Given this list of marker genes Ikbkb, Hnrnpa2b1, Ncoa1, Spink5, Ppp3r1, Clasp1, Fam216b, Wnk3, Dyrk3, Alkal2, Klf4, Arpp19, Acvr1, Rlim, Meox2, Frmpd4, Frmd4a, Plekho2, Pgap4, Dcun1d5 (defective in cullin neddylation 1 domain containing 5), Urb2 (URB2 ribosome biogenesis 2 homolog (S. cerevisiae)), Slc5a7, Ppfibp2, Grpel1, Nmral1, Ppm1k, Coq8a, Ccz1, Mpped1, Phf24, Etf1, Ms4a3, Rpl31, Olfml3, Tead1, Zfp1006, Galk1, Patz1, Pou2af2, Sub1, Ercc4, Dcakd, Pcdh7, Tnk1, Kdm2b, Slc35e3, Ptp4a1, Fam3c, Armc8, Stau1, Dag1, Crebl2, Crim1, Phldb1, Dsg1c, Tgfbr3 (NCBI Gene Id 73753), Retreg1, Csnk2a2, Dtx4, Aldoc, Spop, Hpgds, Wnt3, Nadk, Efr3a, Fam220a, Hdac4, Cacna1e, Klf9, Usp3, Rab30, Obox3, Cpeb2, Esyt3, Cysltr1 (cysteinyl leukotriene receptor 1), Bbx, Denr, Flrt1, here is a description of the gene set: Genes predicted to be targets of miRBase v22 microRNA mmu_miR_6922_3p in miRDB v6.0 with MirTarget v4 prediction scores > 80 (high confidence targets). from publication Chen Y, Wang X (PMID 31504780) studied in species Mus musculus Mouse Gene Set: MIR_6922_3P